Given this list of marker genes DLG4, PYCR1, FBN1, AIP, LOX (lysyl oxidase), COL5A2, ZMPSTE24, SPEN, COPB1, SDR9C7, ENPP1, FBLN5, ABCC6, NIPAL4, ADAMTSL2, LTBP1, ZNRF3, TP53, SMAD3, SULT2B1, FBXO11, WRN, BRAF, COL5A1, COL1A1, HRAS, ALOXE3, TERT, ARMC5, PRKAR1A, CDKN2A, CTNNB1, TGFBR2, TGFB3, ASPRV1, CHD8, LIPN, USP8, USP48, CDH23, ATRX, IPO8, PDE11A, TGFB2 (NCBI Gene Id 7042), ALOX12B, NR3C1, SMARCAD1, TGFBR1, LSS, KDM1A, TGM1, SMAD2, ABCA12, PAH, CUL4B, TNXB, BGN, POLD1, GNAS, CYP4F22, EFEMP2, LMNA, here is a description of the gene set: Human Gene Set: HP_LACK_OF_SKIN_ELASTICITY Lack of skin elasticity studied in species Homo sapiens